Given this list of marker genes Atp6v0c, Atp6v1g2, Atp6ap2, Atp6v0e2, Atp6v1b1, Atp6v1h, Atp6v1c1, Atp6v0d1, Atp6v1e1, Atp6v1b2, Atp6v1g1, Atp6v1g3, Slc17a7, Atp6v1f, Atp6v0a1, Slc9a6, Atp6v1a, Atp6v0a4, Atp6v1d, Atp6ap1, Clcn3, here is a description of the gene set: studied in species Mus musculus The acidification of the synaptic vesicle lumen via transport of protons into the vesicle. The resulting electrochemical gradient powers neurotransmitter loading. Mouse Gene Set: GOBP_SYNAPTIC_VESICLE_LUMEN_ACIDIFICATION